Given this list of marker genes Mapt, Prune1, Map2, Rock2, Dnaaf1, Rp1, Odad2, Nefh, Cfap20 (NCBI Gene Id 70051), Kif18a, Kat2a, Mid1, Clasp2, Rgn, Chmp5, Tpx2, Bicd2, Stmnd1, Cfap206, Chmp1a, Cav3, Wnt3a, Ccdc65, Chmp2a, Tacc1, Trim54, Arhgef2, Mapk15, Sass6 (NCBI Gene Id 72776), Mark4 (MAP/microtubule affinity regulating kinase 4), Taok1, Rock1, Alms1, Bicd1, Cfap45, Cdh5, Fbxw5, Wdr47, Gpsm2, Hsph1, Mapre1, Prkaa2, Chmp2b, Spice1, Sgk1, Togaram1, Stk11, Ttll6, Rnase9, Drc1, Chmp7, Tacc2, Rae1, Cnih2, Cfap298, Eml2, Arhgef7, Cenatac, Ska3, Mapk8, Tacc3, Mid1ip1, Traf3ip1, Stil, Ttc21b, Mkks, Ankrd53, Vps4b, Poc1a, Epha3, Numa1, Cyb5d1, Cav1, Clip1 (NCBI Gene Id 97251), Diaph3, Cyld, Eml3, Ckap5, Slc39a12, Fsd1, Map6d1, Fes, Akap9, Plk2, Cep70, Cdkn1b, Snca, Ccdc40, Ppp1r35, Chmp1b, Ccnl2, Dynlt2b, Tbcd, Catsper1, Tacr1, Bbs1, Htr1a, Cep76, Gda, Met, Defb37, Xrcc3, Tacr2, Slain2, Map1b, Mecp2, D7Ertd443e, Rnf4, Cdk5r1, Lamp1, Azin1, Rbm14, Hdac6, Plk4, Chmp6, Arl2, Tppp, Pafah1b1 (platelet-activating factor acetylhydrolase, isoform 1b, subunit 1), Pkhd1, Spinkl, Ccr6, Cdk5rap2, Pkd1, Pdcd6ip, Sirt1, Eppin, Bmerb1, Gnai1, Bbs2, Anxa5, Klhl42, Efna5, Hnrnpu, Prdm14, Nubp1, Psrc1, Fez1, Xpo1, Bora, Kif21a, Rsph4a, Hspa1b (NCBI Gene Id 15511), Cep295, Trpv4, Chmp4c, Stmn3, Cep120, Cib1, Map1a, Gas2l1, Trim36, Macf1, Tac4, Pde4dip, Bbs4, Cdk2ap2, Cenpj, Diaph1, Ckap2, Cep97, Iqcf1, Spag5, Map6, Cep192, Abl1, Trim46, Rhoa, Cep295nl, Tmem67, Gsk3b, Ccdc88c, Tac2, Nav3, Cdk11b, Ccsap, Spag6l, Ccnf, Spast, Dnah11, Rnase10, Aurkb, Map1s, Fam107a, Plk1, Slain1, Caly, Stmn1, Chmp4b, Inpp5j, Dixdc1, Trim37, Gen1, Dctn1, Fgf13, Cfap43, Defb1, Gba2, Chordc1, Ripor2, Phldb1, Tppp2, Parp3, Clasp1, Kif3a, Nat10, Prkaa1, Hspa1a, Tac1, Mdm1, Mcph1, Phldb2, Cfap69, Rac1, Senp6, Hap1, Adam7, Tubb4a, Stmn2, Camsap3, Rcc1, Mark2, Mapre3, Kif9, Ccdc39, Kat2b, Tex101, Nme7, Bbof1, Map10, Eml4, Nup62, Wfdc6a, Katnb1, Ccdc15, Cep131, Memo1, Fkbp4, Npm1, Map9, Rhot1, Apc, Rps3, Specc1l, Gas2l2, Ska2, Kifc1, Ska1, Or4m1, Camsap2, Git1, Dync1h1, Drg1, Tacr3, Apc2, Stmn4, Clxn, Atat1, Borcs5, Clip3, Agrn, Tpr, Irgc, Atf5, Wdr62, Hdgfl3, Spef1, Gsk3a, Erbb2, Dyrk1a, Chmp3, Chmp1b2, Camsap1 (calmodulin regulated spectrin-associated protein 1), Cltc, Atxn7, Mapre2, Poc1b, Trim58, Ttbk2, Wfdc6b, Ccnl1, Dync1li1, Pak1, here is a description of the gene set: Mouse Gene Set: GOBP_REGULATION_OF_MICROTUBULE_BASED_PROCESS species: Mus musculus Any process that modulates the frequency, rate or extent of any cellular process that depends upon or alters the microtubule cytoskeleton.